Given this list of marker genes Basp1, Foxj1, Yap1 (yes-associated protein 1), Pou3f3, Ctnnb1, Gata3 (GATA binding protein 3), Osr1, Notch1, Ednrb, Magi2, Tshz3, Mmp9, Hes1, Gdnf, Acta2, Jag1, Shh, Ext1, Pdgfb, Fat4, Glis2, Lhx1, Sall1, Mef2c, Ampd2, Ednra, Cd34, Prom1, Six2, Cd24a (NCBI Gene Id 12484), Tcf21, Iqgap1, Nphs2, Wnt9b, Prkx, Wt1, Edn1, Gli3, Ptpro, Klf15, Lamb2, Mtss1, Pax2, Wwtr1, Grem1, Cited1, Amer1, Smo, Lif, Pax8, Gpr4, Nphs1, Adipoq, Wnt4, Asxl1, Foxc2, Ptch1, Myo1e, Podxl, Notch2, Cd2ap, Stat1 (NCBI Gene Id 98183), here is a description of the gene set: Mouse Gene Set: GOBP_CELL_DIFFERENTIATION_INVOLVED_IN_KIDNEY_DEVELOPMENT The process in which relatively unspecialized cells acquire specialized structural and/or functional features that characterize the cells of the kidney as it progresses from its formation to the mature state. species: Mus musculus